The following is a description of a gene set: species: Mus musculus The directed movement of substance through the space in between adjacent cells, rather than through the cells themselves. Mouse Gene Set: GOBP_PARACELLULAR_TRANSPORT, and this is the list of marker genes: Cldn19, Cldn2, Cldn10, Cldn16, Cldn17, Cldn4, Cldn15